The following is a description of a gene set: Human Gene Set: GSE40274_CTRL_VS_FOXP3_AND_HELIOS_TRANSDUCED_ACTIVATED_CD4_TCELL_UP The transcription factor FoxP3 partakes dominantly in the specification and function of FoxP3+ CD4+ T regulatory cells (Tregs), but is neither strictly necessary nor sufficient to determine the characteristic Treg transcriptional signature. Computational network inference and experimental testing assessed the contribution of several other transcription factors (TFs). Enforced expression of Helios or Xbp1 elicited specific signatures, but Eos, Irf4, Satb1, Lef1 and Gata1 elicited exactly the same outcome, synergizing with FoxP3 to activate most of the Treg signature, including key TFs, and enhancing FoxP3 occupancy at its genomic targets. Conversely, the Treg signature was robust to inactivation of any single cofactor. A redundant genetic switch thus locks-in the Treg phenotype, a model which accounts for several aspects of Treg physiology, differentiation and stability. from publication Fu W, Ergun A, Lu T, Hill JA, Haxhinasto S, Fassett MS, Gazit R, Adoro S, Glimcher L, Chan S, Kastner P, Rossi D, Collins JJ, Mathis D, Benoist C (PMID 22961053) studied in species Homo sapiens Genes up-regulated in CD4 T conv: control versus over-expression of IKZF2 and FOXP3., and this is the list of marker genes: TMEM108, CIITA, MBP, TLR7, SYK, CRTC3, SETD2, PAPOLG, MYBPC2, DPP4, CALCRL, PARP8 (poly(ADP-ribose) polymerase family member 8), TK2, PPP1R11, STX6, ZDHHC23, CD86, FRA10AC1, SERTAD1, PRXL2A, PRKCB, C2orf76, MCTP2, OXSR1, CHST15, RNASEH1, TRIM7, HPSE, NRROS, ZNF639 (NCBI Gene Id 51193), LPIN1, RFTN2, FOXP1, CHD3, TSC22D3, CSTF2T, NRM, RAB31, SLC28A2, AFMID, SNX9, KLHL22 (NCBI Gene Id 84861), ZNF398, LRRK2, AP1M1, SPAG9 (NCBI Gene Id 9043), ADPRS, WARS2, GPR137B, CCDC39, UBLCP1, MCUR1, ZNF318, LACTB, OTUD1, SEC24B, TAF5L, ZFP28, STX1A, PDIK1L, SSH1, SMAD2, EVI2B, DAXX, LETM2, CYP4F3, MARVELD2, MTERF2, LTB, CNOT6L, KCNK13, CHD2, CAMKMT (NCBI Gene Id 79823), INSR, ZNF821 (zinc finger protein 821), IL10RA, DSTYK, KCTD10, SYNJ2BP, CTSA, CHMP1B, GALNT4, NSUN6, LLGL1, USP25, PLCG1, PARP3, ACP6, SZT2, MIF4GD, TGIF2, TNRC6C, C1orf54, ZBTB25, EPSTI1, SNAPIN, DCAF15, PTGER4, SLC14A1, ERRFI1, MLLT6, ZBTB6, SMS, SIGIRR, HOPX, SLC25A36, MGST1, GGA2, HDAC10, MIER1, TSPAN2, ZNF566, POLR3B, MFSD1, ZNF764, CNOT2, MFHAS1 (NCBI Gene Id 9258), TRIO, ANKFY1, TIGD2, EZH1, MCCC1, ACAP1, CAPRIN2, WLS, RP9, MYO1C, DIPK1A, MAP3K8, FYCO1 (FYVE and coiled-coil domain autophagy adaptor 1), CREB1, BMP2K, MS4A6A, GCNT1, FAM167A, GIMAP4, AKAP12, UNC5CL, MAPK14, SPNS3, BTBD8, RTP4, SFI1, CNRIP1, DPP7, RABGAP1, GCH1, RIPK3, SOAT1, ABHD6, LRATD2, MANBA, FGD2, ZNF250, SCAF4, IRAK4, NIPAL3, ZNF655, GPR171, MPRIP, ARHGAP26, GALNT6, ASAP1, EPC1, PNPLA7, ARRB1, AIDA, TRIM8, PAIP2, SLC2A3, IFNGR2, BTBD1, CTU2, TPM3, OXA1L, VPS41, GIT2, CISD2, SMIM19, TEC, MTSS1, SUN2, ZNF157, RGL2, GLUL, DHX30, COMMD8, NID1, PLEKHA2, INTS9, SP4, IKZF3, SMURF2, MGA, ZNF493, MAST3 (microtubule associated serine/threonine kinase 3), ARB2A, GIMAP6